The following is a description of a gene set: Presence of only 11 pairs of ribs. Human Gene Set: HP_11_PAIRS_OF_RIBS species: Homo sapiens 11 pairs of ribs, and this is the list of marker genes: ATR, PRDM16, CEP152, HNRNPR, B3GALT6, DNMT3A, TBX5, DONSON, RNU4ATAC, WNK3, SPEN, SCUBE3, HDAC6, SOX2, TOR1A, SNRPB, BMP2, LUZP1, ALDH1A2, TBC1D24, KCNAB2, RPS19, GABRD, SRCAP, MMP23B, UBE4B, SOX9, B3GAT3, PRKCZ, CASZ1, B4GAT1, LBR, CPLANE1, NUP88, GPX4, ATP6V1B2, CHST3, RERE, KYNU, PRIM1, SKI, FLNB, HSPG2, NFASC, RRAS2, TBCK (NCBI Gene Id 93627), CENPJ, NALCN, PDPN